The following is a description of a gene set: Any process that modulates the frequency, rate or extent of cell-substrate adhesion. Cell-substrate adhesion is the attachment of a cell to the underlying substrate via adhesion molecules. species: Homo sapiens Human Gene Set: GOBP_REGULATION_OF_CELL_SUBSTRATE_ADHESION, and this is the list of marker genes: ARHGAP6, CX3CL1, FAM107A, HACD1, FZD4, ABL1, MIR183, PTPRA, FERMT2, TSC1, ACTN4, ITGB1BP1, FUT1, EMILIN1 (NCBI Gene Id 25883), ANGPT2 (angiopoietin 2), CIB1, FLNA, SEMA3E, LIMCH1, ECM2, NPNT, EMP2, S100A10, WDPCP, ROCK1, RHOA, PDGFB, TACSTD2, SPOCK2, FGB, COL26A1, SKAP1, MMP12, PLET1 (NCBI Gene Id 349633), COL16A1, ONECUT2, ARL2, DAB2, NF1, EFNA5, OLFM4, MIR192, CCDC80, NOTCH1, RRAS, GSK3B, ILK, NPY, CCL21, CCN1, PLEKHA2, CRKL (CRK like proto-oncogene, adaptor protein), CCR7, ITGA3, LIMS1, SERPINE1, CD36, ADAM15, BST1, VCL, FBLN1, SMAD3, CDC42, RIN2, CDK6, RASA1, MMP14, P4HB (prolyl 4-hydroxylase subunit beta), TBCD, C1QBP, NID1, DMTN, FOXF1, POLDIP2, ARPC2, LIMS2, CALR, CSPG5, PKP2, VIT, EPHA1, RAC2, NF2, ATXN3, ITGB3, PLPP3, FN1, PLAU, STK4, RELL2, MELTF, CEACAM6, TLN1, DDR1, FERMT1, TRIOBP, ABI3BP, PDPN, MAP4K4, MIR92A1, LDB1, SDC4, BRAF, RREB1, ARHGEF7, CRK, EGFL6, MDK, FBLN2, JUP, ACER2, APOA1, CSF1, RAC3, PHLDB2, CLASP2, DAPK3, AJAP1, MIR503, NRP1, PTK2, BCL6, PKHD1, CASK, THBS1, EPB41L5, EGFLAM, ACVRL1, PTEN, CCL28, DISC1, ROCK2, ITGA5, SRC, UNC13D, MYADM, DMP1, WNT1, GFUS, SPOCK1, RHOD, NPY2R, HOXA7, RSU1, CLASP1, PRKCE, CASS4, MACF1, THY1, VWC2, APOD, RAC1, MIR29C, JAG1, TESK1, AP1AR, DOCK5, VEGFA, EPHA3, MYOC, NEDD9 (NCBI Gene Id 4739), ONECUT1, GPM6B, SLC9A1, SPRY4, FGG, GCNT2, LEF1, CORO2B, GREM1, SFRP1, AGR2, PEAK1, WASHC2C, DUSP3, FZD7, GBP1, DOCK1, FGA, PTPRO, COL1A1, PLG, WNT4, ALOX15, PTPRJ, POSTN, CARMIL1, TEK, MIR939, DAG1, KDR, COL8A1, MYF5, PTPN1, HTN1 (NCBI Gene Id 3346), DLC1, SLK, PTK2B, CORO1C, PIK3CB, EFEMP2, MINK1, CDKN2A, NEXMIF, VTN, JAK2, CFL1, PREX1, KANK1, PIK3R1, CAMSAP3, DUSP22, UTRN, HSD17B12, NDNF, BCL2, HRG, CCL25, PPM1F, EDIL3, CD3E, CDH13, RCC2, ACTG1 (NCBI Gene Id 71), HAS2